The following is a description of a gene set: Human Gene Set: GSE13411_NAIVE_VS_IGM_MEMORY_BCELL_DN Genes down-regulated in comparison of naive B cells versus IgM-memory B cells. Enhanced secondary Ab responses are a vital component of adaptive immunity, yet little is understood about the intrinsic and extrinsic regulators of naive and memory B cells that results in differences in their responses to Ag. Microarray analysis, together with surface and intracellular phenotyping, revealed that memory B cells have increased expression of members of the TNF receptor, SLAM, B7 and Bcl2 families, as well as the TLR-related molecule CD180 (RP105). Accordingly, memory B cells exhibited enhanced survival, proliferation and Ig secretion, as well as entered division more rapidly than naïve B cells in response to both T-dependent and T-independent stimuli. Furthermore, both IgM and isotype switched memory B cells, but not naïve B cells, co-stimulated CD4+ T cells in vitro through a mechanism dependent on their constitutive expression of CD80 and CD86. This study demonstrates that upregulation of genes involved in activation, co-stimulation and survival provides memory B cells with a unique ability to produce enhanced immune responses and contributes to the maintenance of the memory B cell pool. species: Homo sapiens from publication Good KL, Avery DT, Tangye SG (PMID 19124732), and this is the list of marker genes: IGLV1-44, SRD5A1, MOCS3, ORAI2, FAH, ISG15, MCM3, AKR1D1, ENTPD4, PGAM1 (phosphoglycerate mutase 1), ETFDH, TFF2, SLC5A12, CDK2AP1, LY96, GOLGA8A, LGMN, SPEG, RBFA (ribosome binding factor A), LMO4 (LIM domain only 4), STK10, AKT2, BTN3A2, ZFYVE21, RO60, FGL2, LDHA, ALDOA, PPM1G, COL4A3, STK39, CR2, TNNC1, GAPDH, INTS14, CCL5, TARS2, PPIH, CRCT1, PSMC4, VPS35, CERS2, NADK, BMP2, PDE3A, SLC9A5, EHD3, JCHAIN, PPFIBP2, ZNF682, DEPDC5, CHP1, CD27, CCR2, PPP1R14B, TRIM10, CAPNS1, MZF1, KLF6, EPRS1, BBOX1, PGK1, TNFSF9, SLC25A1, MTMR14, PGD, PABPC1, LTB, NAP1L4, COPE, FUT8, PTPN18, CYP39A1, TPI1, KCTD5, PCBD1, LDHB, EML2, RAC1, GSTM2, SPAG7, PAX5, MYDGF, MDH2, DELEC1, DAAM1, ATP6V0D1, NAGPA, NDUFA9, SPAG1, MZB1, TSPAN14, CBX6, RBM47, BLMH, KANK1, PSMF1, MACROD1, GPM6A, DRAM1, CAMKK2, IMP4, APEH, RNPEP, PLAAT3, PRAMEF10, LOX, ACY1, SCRN1, YIF1A, TBC1D10B, MRPL44, EDC3, AEBP1, P2RY11, IGHM, SSTR5, MARCKS, UQCRC1, MAOB, H3C11, MFSD12, SLC35C1, TERF2, HOXD10, HK1, GALNT10, NSMCE4A, ZMIZ1, ADGRE2, ANAPC15, TPD52L2, HOXB5 (homeobox B5), PEF1, ELMO2 (NCBI Gene Id 63916), IFI35, CEP250, PEPD, SYK, AIP, HOOK1, NAALADL1, NEBL, PPP1R13B, ZNF91 (zinc finger protein 91), ZBBX, TFDP1, MTF1, EIF3G, NACC2, SDHAF1, UQCR11, SPRED2, AP2M1, PIN1, CTSC, MYO1D, JAM3, VOPP1, KLF12, TLE3, THEMIS2, TALDO1, DHRS1, FYN, LPXN, AKR1C2, CRELD2, CLUHP3, VDAC1, ABCC1, TTR, LAMB1, BAK1, SSX2IP, ATXN1, TGIF2, EIF2AK1, RBMS1 (RNA binding motif single stranded interacting protein 1), IDH2 (isocitrate dehydrogenase (NADP(+)) 2), KEAP1, UST (uronyl 2-sulfotransferase), SLC35E2A, ABHD6, DCAF11, RBCK1, DCPS, CDT1, MYC, NUP93, PMPCA, DOK3, MRPL12 (mitochondrial ribosomal protein L12), EIF4B, RUFY1, BGLAP, BANF1 (NCBI Gene Id 8815), NR5A2